The following is a description of a gene set: studied in species Homo sapiens A condensed cytoplasmic structure that covers the nucleus of mammalian spermatozoa except for a narrow zone around the insertion of the tail. It shows two distinct regions, a subacrosomal layer and, continuing caudally beyond the acrosomic system, the postacrosomal sheath. The perinuclear theca has been considered a cytoskeletal scaffold responsible for maintaining the overall architecture of the mature sperm head; however, recent studies indicate that the bulk of its constituent proteins are not traditional cytoskeletal proteins but rather a variety of cytosolic proteins. Human Gene Set: GOCC_PERINUCLEAR_THECA, and this is the list of marker genes: CCIN, CYLC2, CYLC1 (cylicin 1), ACTL9, WBP2NL